Given this list of marker genes POR, ALKBH4, PHF2, CYP3A5, MMACHC, CYP3A7, CYP3A43, JMJD6, CYP2D6, CYP1A2, ALKBH1, CYP3A4, CYP2C8, CYP2C9, here is a description of the gene set: studied in species Homo sapiens Human Gene Set: GOBP_DEMETHYLATION The process of removing one or more methyl groups from a molecule.